Given this list of marker genes Csf2, Bcl2l11, Col2a1, Il2, Dapk3 (NCBI Gene Id 13144), Bcl2a1c, Tnf, Ngf, Bcl2l1, Gpr62, Cx3cl1, Stradb, Moap1, Il4, Igf1, Nrg1, Ppp2r1a, Gsk3a, Eya3, Gfral, Il1a, Gdnf, Unc5b, Nf1, Mknk2 (MAP kinase-interacting serine/threonine kinase 2), Bcl2l10, Bag3, Bcl2a1b, Mknk1, Il7, Eya4, Tert, Inhba, Agap2, Bok, Bad, Hspa1b, Itgav, Fyn, Fas, Lcn2, Bcl2, Gpr61, Ppp1ca, Eya1, Map2k5, Clca3a2, Il3 (NCBI Gene Id 16187), Fgfr1, Bcl2a1a, Fadd, Wwox, Erbb3, Fgf10, Prdx2, Ppp2r1b, Bak1, Klf4, Ret, Snai2, Htra2, Ctnna1, Tgfb2, Bax, Bcl2l2, Gata1, Mapk7, Sgk3, Il1b, Bcl2a1d, Gas1, Eya2, Mcl1, Srpx, Foxo3, Gsk3b, Kitl, Casp2, Ripk1, Jak3, here is a description of the gene set: studied in species Mus musculus The series of molecular signals initiated by the absence of a ligand or the withdrawal of a ligand from a receptor. Mouse Gene Set: GOBP_SIGNAL_TRANSDUCTION_IN_ABSENCE_OF_LIGAND